Given this list of marker genes RPL27A, DPH5, ARSH, BGLAP, JMJD6, F7, ARSA, EIF5A2, FN3K, SUMF2, GAS6, EEF2, SUMF1, PROZ, F8, RIOX2, DPH3, DHPS, DPH2, ASPH, RWDD1, ARSK, JMJD7, STS, ZC3H15, DPH1, ARSL (arylsulfatase L), F2, JMJD4, KDM8, TPST2, DRG2, F9, PROC, GGCX, ARSJ, DPH6, FN3KRP, PROS1, F10, DNAJC24, ARSD, OGFOD1, EIF5A, DOHH, DPH7, RPL8, ICMT, ETF1, ARSB, DRG1, RPS23, U2AF2, ARSF, RCCD1, TPST1, FURIN, RPS6, ARSG, RIOX1, ARSI, here is a description of the gene set: Reactome Pathway: Gamma carboxylation, hypusinylation, hydroxylation, and arylsulfatase activation species: Homo sapiens part of: Post-translational protein modification After translation, many newly formed proteins undergo further covalent modifications that alter their functional properties and that are essentially irreversible under physiological conditions in the body. These modifications include the vitamin K-dependent attachment of carboxyl groups to glutamate residues and the conversion of a lysine residue in eIF5A to hypusine, the conversion of a histidine residue in EEF to diphthamide, and the hydrxylation of various amino acid side chains.